The following is a description of a gene set: Human Gene Set: KEGG_MEDICUS_REFERENCE_CHONDROITIN_SULFATE_BIOSYNTHESIS Pathway Definition from KEGG: G00157 -- CSGALNACT1/2 >> CHSY1/3,CHPF -> Chondroitin -- CHST3/7 -> Chondroitin_6-sulfate studied in species Homo sapiens Chondroitin sulfate biosynthesis. Pathway ID: N01580. Pathway type: Reference. Pathway class: nt06029 Glycosaminoglycan biosynthesis., and this is the list of marker genes: CHSY3, CHST3, CHSY1, CHPF, CHPF2, CSGALNACT1, CSGALNACT2, CHST7